The following is a description of a gene set: Transcription factors that regulate quiescence, proliferation, and homing of lymphocytes are critical for effective immune system function. In the present study, we demonstrated that the transcription factor ELF4 directly activates the tumor suppressor KLF4 downstream of T cell receptor (TCR) signaling to induce cell cycle arrest in naive CD8+ T cells. Elf4- and Klf4-deficient mice accumulated CD8+CD44hi T cells during steady-state conditions and generated more memory T cells after immunization. The homeostatic expansion of CD8+CD44hi T cells in Elf4-null mice resulted in a redistribution of cells to non-lymphoid tissue due to reduced expression of the transcription factor KLF2, and the surface proteins CCR7 and CD62L. This work describes the combinatorial role of lymphocyte-intrinsic factors in the control of T cell homeostasis, activation and homing. from publication Yamada T, Park CS, Mamonkin M, Lacorazza HD (PMID 19412182) Human Gene Set: GSE15324_ELF4_KO_VS_WT_ACTIVATED_CD8_TCELL_UP species: Homo sapiens Genes up-regulated in comparison of activated CD8 T cells from ELF4 defficient mice versus those from wild type animals., and this is the list of marker genes: MIB2, HLA-B, FBXL6, ERI2, SCAPER, GTF2E2, FAM114A2, YAF2, GPR25, TFPI, YPEL2, KLHDC1, BEND4, ELP4, CAAP1, PFN2, ARMC1, DCAF6, FKBPL, ARHGEF19, AP4M1, PCCA, CRYZ, IL4, RAB9A, ASB2, ZCCHC10, TRPC1, SEMA4C, RNF103, AKAP7, PATL2, LONP1, EHD1, NICN1, AVPI1, IER3, FAM210A, IZUMO1R, ARMCX1, ACBD6, TG (NCBI Gene Id 7038), CYRIB, CRISPLD2, MYOM2, PPIP5K1, HEATR5A, PLPP5 (NCBI Gene Id 84513), TMBIM1, NNAT, SSX2IP, PLCXD2, YES1, KIF5C, GALNT11, AGPAT4, TMEM199, MLLT11, PTGER2, FAM8A1, BTBD7, ABTB2, CRBN, CMTM6, ARFIP2, C9orf85 (NCBI Gene Id 138241), XPR1, AP3S1, PLSCR3, TBC1D9B, GNB4, SEC23A, RAMP1, IL17A, LBH, GTPBP2 (NCBI Gene Id 54676), CLU, HNRNPUL1, MACROD2, TPI1 (NCBI Gene Id 7167), CEP97, EGLN3, TTL, ACAT1, SKAP2, KCTD3, PGS1, SENP7, APOF, TMTC4, PPIE, MRPS15, ARL2, CHP1, ARMCX6, PIKFYVE, FAM91A1, DIP2A, ADAM9, IL1R1, MIB1, CLYBL, EPS15, CTH, FBXW9, TXNRD3, RLF, GLB1L2, APOOL, ELL2, CDK5RAP1, DNAJC16, NECTIN2, GLO1, DLG3, BET1, EIF2AK4, PEX13, GLOD4, CINP, LIF, TTC9C, IL5, SNHG10, GPRASP2, CBX3, ARL3, GPRASP3, DTX1, DDX17, SMIM30, KIF2A, ELP3 (NCBI Gene Id 55140), GOLM2, UBQLN1, DENND10, DUSP22, CDC14B, SPOPL, ARHGEF4, HIPK2, POMGNT2, ETFBKMT, RBPJ, MAPK9, PRMT2, GTF3C3, TRIP4, CCNH, ZNF516, BASP1, ENPP2, NUBPL, RBP1, FPGS, SDF4, NIPSNAP1, FYTTD1, BAG4, PIM1, TRAPPC8, ASB7, PIK3R2, NAT9, CHCHD6, AKR1C3, C8orf74 (NCBI Gene Id 619350), TRIM23, RPL7L1, CCDC47, NCOA7, FUT11, HARBI1, MEX3C, FAM135A (family with sequence similarity 135 member A), ELOVL4, NEPRO, METTL15, REPIN1, RSBN1, GSTM4, GLG1, RPRD1A, TMEM263, HYCC1, ASIC3, SLC35G1, VAMP4, KCNK10, GATD1, ALDH9A1, SMIM14, DPY19L3, GORASP1, ARFIP1, MCFD2, SLC25A15, EIF2A, LRIG1, KRR1